Given this list of marker genes Kcnn4, Kcnj10, Tmem38a, Kcnh5, Kcnc3, Kcnk6, Kcnk13, Kcna3, Atp1a4, Kcnmb3, Kcnip2, Slc17a6, Lrrc26, Grik3, Kcnt1, Gria2, Slc9c1, Kcnn1, P2rx7, Slc12a3, Slc24a1 (NCBI Gene Id 214111), Kcnk1 (NCBI Gene Id 212682), Slc12a9, Dpp6, Kcna5, Pias3, Kcnc2, Wnk3, Hcn2, Sgk2, Kcng4, Ank2, Cnga2, Abcc9 (ATP-binding cassette, sub-family C member 9), Kcna6, Adrb2, Kcnj12, Kcns3, Kcnj2, Wnk2, Slc12a6, Slc12a5, Dlg1 (NCBI Gene Id 320792), Kcnj1, Kcnn2, Slc5a3, Slc9a7, Kcnq3, Kcnq1, Kcnh8, Slc9a1, Slc24a3 (NCBI Gene Id 94249), Grik4, Kcnk16, Kcnc4, Slc12a8, Atp4b (ATPase, H+/K+ exchanging, beta polypeptide), Cav3, Atp1a2 (ATPase, Na+/K+ transporting, alpha 2 polypeptide), Kcns1, Kcnk15 (NCBI Gene Id 278871), Kcnj16, Kcnip1, Flna, Kcna1, Kcnv2, Atp1b3, Kcnma1, Scn2b (NCBI Gene Id 72821), Kcnn3, Wnk1 (WNK lysine deficient protein kinase 1), Atp4a, Kcnh7, Atp1a1, Ccdc51, Slc9a3, Slc17a7, Kcns2, Sgk1, Kcnk3, Sgk3, Kcna7, Kcnk18, Slc9a9, Trpm5, Kcna2, Kcnk9, Lrrc55, Tmem38b, Kcng1, Slc9a5, Slc12a2, Lrg1, Kcnmb4, Kcnab3, Kcnj15, Kcna4, Mcoln1, Kcnb2, Atp12a, Kcnj13, Kcnab2, Kcnq5 (NCBI Gene Id 77687), Slc9a4, Kcnk7, Grik5, Prkcz, Fxyd4, Pkd2l1, Hcn4, Grik2, Snap25, Kcnj9, Kcnc1, Kcnh1, Kcnj6 (potassium inwardly-rectifying channel, subfamily J, member 6), Hcn1, Kcnip3, Slc12a1, Kcnh3, Ensa, Slc24a4, Aqp1 (aquaporin 1), Kcnh2, Kcnj11, Abcc8, Slc9a2 (solute carrier family 9 (sodium/hydrogen exchanger), member 2), Kcnk2, Kcnf1, Dpp10, Cpox, Lrrc52, Kcnb1, Atp1a3, Ywhae, Kcnj4, Kcnk4, Slc9a8, Tmem175, Kcnip4, Cav1, Grik1, Slc12a4, Wnk4, Slc24a2, Atp1b1, Kcnd2, Hcn3, Kcne2, Akt1, Mcoln3, Kcnt2, Kcnmb1, Atp1b2, Kcnd1, Kcnj3 (NCBI Gene Id 16519), Sumo1, Kcnj14 (potassium inwardly-rectifying channel, subfamily J, member 14), Kcnq2, Kcna10 (NCBI Gene Id 242151), Kcnv1, Kcnh4, Tmco3, Kcnk5, Akap9, Kcnab1, Kcne4 (potassium voltage-gated channel, Isk-related subfamily, gene 4), Kcnq4, Kcnu1, Slc12a7, Kcnk12, Arpp19, Slc24a5, Nedd4l, Amigo1, Kcnh6, Kcne5, Slc9a6, Kcnmb2 (NCBI Gene Id 73119), Kcnj5, Kcnd3, Pkd2, Kcnk10, Kcne3, Kcng2, Kcne1, Fxyd5, Lrrc38, Kcnj8, Kcng3, here is a description of the gene set: studied in species Mus musculus Enables the transfer of potassium ions (K+) from one side of a membrane to the other. Mouse Gene Set: GOMF_POTASSIUM_ION_TRANSMEMBRANE_TRANSPORTER_ACTIVITY